The following is a description of a gene set: from publication Amit I, Garber M, Chevrier N, Leite AP, Donner Y, Eisenhaure T, Guttman M, Grenier JK, Li W, Zuk O, Schubert LA, Birditt B, Shay T, Goren A, Zhang X, Smith Z, Deering R, McDonald RC, Cabili M, Bernstein BE, Rinn JL, Meissner A, Root DE, Hacohen N, Regev A (PMID 19729616) Human Gene Set: GSE17721_CPG_VS_GARDIQUIMOD_16H_BMDC_DN mouse primary BMDCs were stimulated with tlr ligands and gene expression changes were profiled on Affymetrix arrays Genes down-regulated in comparison of dendritic cells (DC) stimulated with CpG DNA (TLR9 agonist) at 16 h versus DC cells stimulated with Gardiquimod (TLR7 agonist) at 16 h. species: Homo sapiens, and this is the list of marker genes: COL5A3, PRRC1, EMC7, S100G, CACYBP, ESRP1, PRMT7, RAB38, EIF2AK3, SIGIRR, DAPK1, EDEM3, PARG, SLPI (secretory leukocyte peptidase inhibitor), PAG1, RASGRP1, UBE2H, CDIPT, WASHC4, ARHGDIB, AMMECR1, FAM222B, ATP1A1, GTPBP1, CP, IGDCC3, ELAVL3, MRAS, NQO1, ANKZF1, NOP9, CEACAM21, NDUFB8, CCRL2, COG8, ABAT, MLLT10, TMEM135, STXBP3, SLC2A5, MTERF3, KICS2, FKBP11, EBF3, SCN2A, PTGR1 (NCBI Gene Id 22949), GRP, DIPK2A, TMEM199, SELENOP, CD38, TMEM38B, ERO1A, CALCOCO2, ANO1, XBP1 (NCBI Gene Id 7494), HNRNPAB, ST3GAL2, GINS1, MYO1B, POMC, TMEM179B, LRWD1, SLC7A7, GK, PNPO, TF, RNF149, SH3GL1, ERMP1, HLCS (holocarboxylase synthetase), FAM120A, SLC39A4, BAZ2A, ARF6, CITED2, HMG20A, MARCO, SOX4, CCDC28A, P4HA1, C1QL1 (complement C1q like 1), PLAGL2, PDHA2, HLA-C, RNF5, CRADD, USP1, HPRT1, CYP2J2, PPP1R14A, FOSL1, ETF1, DAB1, ZNF280D, DDX17, AKR1B15, SORBS3, CAPZA1, MSN, PARP16 (poly(ADP-ribose) polymerase family member 16), TANC1, PIK3CG, CCNI (NCBI Gene Id 10983), FDFT1, NBEA (neurobeachin), MTF2, STRN3, HAPLN2, EML5, TIMM8A, ITGA4, TNKS2, UBE4B, PROKR1, TAC1, ATP6V1A, PPIC (peptidylprolyl isomerase C), APOC2, WIPI1, P2RY6, USP14, VPS37A, FUT10, IBTK, B3GNTL1, SLC31A1, SERPINB2, CLPX, SNRNP70, ATP6V1C1, WNT5A, YEATS4, PDCD6IP, HPS1, LHX5, TRIM28, YWHAZ, KCNE2 (NCBI Gene Id 9992), XPR1, AK3, LTC4S, PSMG3, KCND3, POLD2, TRIM41, TK2, APRT, UBE2B, CCT5, ARL6, MCUB, ADGRG3, UBOX5 (NCBI Gene Id 494512), ZBTB33, MAG, CTBP1, MCEE, UBAC2, EVI5, RIPK1, SLC25A45, HP, CHST15, TENM1, REXO1, ABI1, TECR, USO1, SIN3A, ADRB2, RPL38, ROCK2, ARTN, CAV1, FAM53A, ARID5A, SORCS1 (sortilin related VPS10 domain containing receptor 1), KLHL9, XIST, PILRA, DNER, EFS, TRMT112, INTS7 (NCBI Gene Id 25896), NAT9, FAM234B, CLEC4A, PPP1R17, GCDH, NR1D2, FAM98A, TRIM2, NDEL1 (nudE neurodevelopment protein 1 like 1), UPP1, B3GNT5, ITIH4, SMPD2, HNRNPF